The following is a description of a gene set: species: Mus musculus Mouse Gene Set: GOBP_GLUCOSE_CATABOLIC_PROCESS The chemical reactions and pathways resulting in the breakdown of glucose, the aldohexose gluco-hexose., and this is the list of marker genes: Bad (NCBI Gene Id 12015), Slc25a12, Foxk1, Pgk1, Pfkm, Pfkp, Pfkfb2, Bcl2l13, Tpi1, Pfkl, Trp53, Lrp5, Src, Hk1, Eno2, Gapdh, Adcy10, Aldoa, Ldha, Hk2, Gpi1, Eno1, Foxk2, Eno1b, Tigar, Pgam2, Gck, Eno3, Pkm, Actn3